Given this list of marker genes THBS3 (thrombospondin 3), RBP1 (retinol binding protein 1), FHL1, NFIX, MAPT, ACVRL1, MEOX2, TP53BP2, PDE4DIP, NHERF2, LLGL2, SCGB3A2, C5, MRPS18B, APLN, TNFRSF19, DPP4, PEX16, ZBP1, NRP1, ADH1A (alcohol dehydrogenase 1A (class I), alpha polypeptide), EPB41L3, ABCG1, PON1, SFTPC, ADGRE5, FASN, LTBP4, CDH13, CAV1, HLA-DRB1, HEY1, SFTPB, ANTXR1, CHST2, FGF1, CDKL2, RSU1, CLEC10A, ICAM2, TIMM17A, CYP2F1, BMP2K, CXCL12, OGT, APLNR, ALAS1, here is a description of the gene set: The role of nitric oxide (NO) in acute lung injury remains controversial. Although inhaled NO increases oxygenation in clinical trials, inhibiting NO-synthase (NOS) can be protective. To examine the latter, nickel-exposed mice were treated with saline or NOS inhibitor, N(G)-nitro-L-arginine methyl ester (L-NAME). Initial microarray analysis of nickel-induced gene expression of saline-treated mice revealed increased inflammatory mediator, matrix injury-repair, and hypoxia-induced factor-mediated sequences and decreased lung-specific (e.g., surfactant-associated protein B and C) sequences. Compared with saline control, L-NAME-treated mice had enhanced survival with attenuated serum nitrate/nitrite, endothelial NOS activity, and lavage neutrophils and protein. Although initial cytokine (i.e., interferon-gamma, interleukins-1beta and -6, macrophage inflammatory protein-2, monocyte chemotactic protein-1, and tumor necrosis factor-alpha) gene expression was similar between groups, subsequent larger cytokine increases only occurred in saline-treated mice. Similarly, surfactant protein gene expression decreased initially in both groups yet was restored subsequently with L-NAME treatment. Interestingly, the role of inducible NOS (iNOS) in these responses seems minimal. iNOS gene expression was unaltered, iNOS activity and nitrotyrosine residues were undetectable, and an iNOS antagonist, aminoguanidine, failed to increase survival. Rather, systemic L-NAME treatment appears to attenuate pulmonary endothelial NOS activity, subsequent cytokine expression, inflammation, and protein permeability, and thereby restores surfactant gene expression and increases survival. Genes down-regulated in the mouse model of acute lung injury induced by inhaling nickel sulfate. studied in species Mus musculus from publication McDowell SA, Gammon K, Zingarelli B, Bachurski CJ, Aronow BJ, Prows DR, Leikauf GD (PMID 12540486) Human Gene Set: MCDOWELL_ACUTE_LUNG_INJURY_DN